The following is a description of a gene set: part of: Signaling by ERBB2 ERBB2:EGFR and ERBB2:ERBB4 can directly recruit GRB2:SOS1 complex through phosphorylated C-tail tyrosines of EGFR (Y1068 and Y1086) and ERBB2 (Y1139) that serve as docking sites for GRB2, which, again, results in SOS1-mediated guanyl-nucleotide exchange on RAS and activation of RAF and MAP kinases. Reactome Pathway: GRB2 events in ERBB2 signaling species: Homo sapiens, and this is the list of marker genes: NRG3, GRB2, NRG4, EGFR, NRG2, NRAS (NRAS proto-oncogene, GTPase), NRG1 (NCBI Gene Id 653104), ERBB4, BTC (NCBI Gene Id 685, betacellulin), EGF, HBEGF, EREG, HRAS, KRAS, SOS1, ERBB2